Given this list of marker genes Cobl, Wnt3, App, Spart, Wnt3a, here is a description of the gene set: studied in species Mus musculus The process in which outgrowths develop from the axons of intact undamaged neurons. Mouse Gene Set: GOBP_COLLATERAL_SPROUTING_IN_ABSENCE_OF_INJURY